Given this list of marker genes Pah, Ero1a, Glul, Fh1, Gpt, P4ha2, Gcsh, Aass, Gcat, Pycr1, Tdh, Qprt, Shmt2, Baat, Acad8, Nadsyn1, Hpd, Adhfe1, Aldh4a1, Ass1, Il4i1 (interleukin 4 induced 1), Oca2, Gad2, Bcat2, Nit2, Atp7a, Slc38a8, Ldc1, Bhmt, Spr, Ero1b, Mccc2, Comt, Gldc, Cth, Pipox, Amdhd1, Oat, Oaz1, Aspg, Psph, P4hb, Mmut, Mat1a, Mpst, Acadsb, Aldh8a1, Hmgcl, Nags, Ddah1, Pcbd1, Aldh5a1, Thap4, Cln3, Slc25a12, Aldh18a1, Slc7a11, Htt, Hao1, Tph2 (NCBI Gene Id 237554), Ftcd, Aasdhppt, Bckdk, Dlst, Phgdh, Scly, Prodh, Sardh, Hsd17b10, Ido1, Kmo (kynurenine 3-monooxygenase), Got2, Asnsd1, Mthfd1, Mccc1, Dao, Icmt, Gstz1, Gnmt, Hdc, Thnsl2, Slc39a8 (solute carrier family 39 (metal ion transporter), member 8), Mthfr (methylenetetrahydrofolate reductase), Tyrp1, Tha1, Kyat1, Dglucy, Mri1, Ido2, Park7, Otc, Aspa (aspartoacylase), Cdo1, Gclm, Pcbd2, Cad, Ttc36, Th, Iyd, Psat1, P4ha1, Acmsd, Aadat, Hal, Hoga1, Ucp2, Kyat3, Egln2, Mtrr, Mecp2, Blmh, Ilvbl, Tdo2, Bloc1s6, Arg1, Pycr2, Atp2b4, Sirt4, Acat1, Sephs1, Azin2, Pycr3, Asrgl1, Agxt2, Atf4, Sdsl (serine dehydratase-like), Slc45a2, Hgd, Ahcyl, Kynu, Sephs2, Glud1, Agxt, Hibch, Dpep1, Fpgs, Gpt2, Apip, Gls2, Plod2, Mthfd2l, Cyp2d22 (cytochrome P450, family 2, subfamily d, polypeptide 22), Noxred1, Ahcy, Prdx4, Nos2, Aldh6a1, Got1l1, Asl, Adss2, Srr, Bhmt2, Ggt1, Enoph1, Ndp, Gamt, Amt, Slc7a7, Plod3 (NCBI Gene Id 26433), Hibadh, Adi1, Mtap, Fah, Gclc, Cbs, Azin1, Lgsn, Slc25a2, Nmnat2, Slc38a1, Ppat, Odc1, Csad, Mthfsl, Nos1, Bhmt1b, Pemt, Hnf4a, Hmgcll1, Agmat, Sds, Mtr, Shmt1 (serine hydroxymethyltransferase 1 (soluble)), Arg2, Afmid, Dct, Gcdh, Txnrd1, Gls, Gfpt2, Cps1, Tat, Nos3, Ddo, Gart, Bcat1 (NCBI Gene Id 12035), Qdpr, Prodh2, Pfas, Got1, Auh, Apc, Glyat, Nr1h4 (NCBI Gene Id 20186), Asns, Gad1, Ivd, Nat8l, Adss1, Uroc1, Crtap, Haao, Pcmt1, Atcay, Nox4 (NCBI Gene Id 50490), here is a description of the gene set: Mouse Gene Set: GOBP_ALPHA_AMINO_ACID_METABOLIC_PROCESS species: Mus musculus The chemical reactions and pathways involving an alpha-amino acid.